Given this list of marker genes Fgf9, Gprc5a, Dnai7, Nkx2-9, Trp73, Fen1, Ppp2r1a, Scrib, Rassf1, Slc33a1, Tnk1, Klf14, Tbrg1, Mapk14, Ogg1, Cdkn2c, Ssbp2, Tsc2, Braf, Kras, Btg3, Xpa, Foxm1, Nudt1, Usp44, Smad9, Lzts1, Cep57, Trp63 (NCBI Gene Id 22061), Dclre1a, Cbx7, Tpx2, Trp53, Xpc, Becn1, here is a description of the gene set: from publication Motenko H, Neuhauser SB, O'Keefe M, Richardson JE (PMID 26092688) Mouse Gene Set: MP_INCREASED_LUNG_ADENOMA_INCIDENCE species: Mus musculus Mouse genes annotated to increased lung adenoma incidence (MP:0002048) retrieved from the Mouse Genome Informatics database via MouseMine